Given this list of marker genes Cyp1a2, Ces1d, Lss, Aldh1a3, Aldh1a2, Adh4, Cyp3a11, Rdh7, Rbp1, Rdh5, Lrat, Aldh1a7, Cyp26a1, Akr1c18, Sdr9c7, Adh7, Cyp2w1, Cyp26c1, Bco2, Lpl, Rarres2, Rdh10, Rdh8, Plpp6 (NCBI Gene Id 74411), Ces1f, Ces2c (carboxylesterase 2C), Adh5, Rpe65, Fdps (NCBI Gene Id 99573), Clps, Dhrs7, Cyp3a16, Bco1, Cyp2s1, Sdr16c5, Rdh13, Cyp26b1, Cyp3a41b, Cyp2j6, Aldh3a2, Rdh9, Rdh19, Ces2a (NCBI Gene Id 102022), Star (steroidogenic acute regulatory protein), Fdft1, Htra2, Ttr, Cyp2e1, Cyp2c55, Strap, Ldlr, Lipa, Hmgcs1, Crh, Dgat1, Rdh16f2, Adh6b, Rdh16, Rbp4, Pnpla2, Cyp3a41a, Rdh12, Rbp2, Ces1e, Pecr, Lipe, Egfr, Klf9, Rdh11 (retinol dehydrogenase 11), Lcn5, Pnlip, Dhrs4, Adh6a, Prmt3, Sp1, Crabp2, Retsat, Hmgcs2, Dgat2 (NCBI Gene Id 67800), Rdh1, Akr1b1, Ces2e, Aldh1a1, Aldh8a1, Cyp1a1, Abca4, Dhrs3, Adh1, Rdh14, Cyp1b1, Dhrs9, Cyp3a44, Hsd17b6 (hydroxysteroid (17-beta) dehydrogenase 6), Ggps1, Plb1, Isx, Awat2, here is a description of the gene set: studied in species Mus musculus The chemical reactions and pathways involving terpenoids, any member of a class of compounds characterized by an isoprenoid chemical structure and including derivatives with various functional groups. Mouse Gene Set: GOBP_TERPENOID_METABOLIC_PROCESS